The following is a description of a gene set: from publication Zhong S, Zhang S, Fan X, Wu Q, Yan L, Dong J, Zhang H, Li L, Sun L, Pan N, Xu X, Tang F, Zhang J, Qiao J, Wang X (PMID 29539641) species: Homo sapiens Human Gene Set: ZHONG_PFC_C2_ASCL1_POS_ASTROCYTE, and this is the list of marker genes: NDUFA12, ASCL1, HPF1, TRIB2, PPP4R3B, DDIT4